The following is a description of a gene set: Human Gene Set: GOBP_REGULATION_OF_PROTEASOMAL_UBIQUITIN_DEPENDENT_PROTEIN_CATABOLIC_PROCESS studied in species Homo sapiens Any process that modulates the frequency, rate or extent of the breakdown of a protein or peptide by hydrolysis of its peptide bonds, initiated by the covalent attachment of ubiquitin, and mediated by the proteasome., and this is the list of marker genes: TF, UBE2K (ubiquitin conjugating enzyme E2 K), PBK, TAF1, PLK3, PABPN1L, DDA1, ZFAND2A, LRRK2, DDRGK1, GSK3B, FBXO22, DET1, NKD2, DESI1, SENP1, KLHL40, CSNK1E, STUB1, USP7, ARHGAP5-AS1, ZER1 (zyg-11 related cell cycle regulator), GLMN, MAPK9, CDC20B, SH3RF3, BAG2, UBXN1, XPO1, RAD23A, HSPBP1, CAMLG, SMAD7, AURKA, ZYG11B, RACK1, AKT1, DVL1, RAD23B, CDK2, CSNK2A2, GNA12, TRIM39 (NCBI Gene Id 56658), RPL11, EIF3H (NCBI Gene Id 8667), PRKN, PARK7, SOCS4 (NCBI Gene Id 122809), RYBP, SUMO2, PAQR3, OGT, NOP53, PABIR1, PSMD10, CBFA2T3, MTM1, AXIN2, HSPA1B, HFE, MDM2 (MDM2 proto-oncogene), PSEN1 (NCBI Gene Id 5663), GABARAP, FBXW8, BBS7, FHIT, WAC, HSPA1A (heat shock protein family A (Hsp70) member 1A), SH3RF1, SHH, IL33, SIRT2, CSNK2B, UBQLN4, PIAS1, UFL1, CEBPA (CCAAT enhancer binding protein alpha), STYX, USP26, MAP1A, BAG6, PHF20L1, PLK1, BAG5, CSNK1A1, RCHY1, GIPC1, DAB2, SOCS5, VCP, COMMD1, CLU, NUB1, TRIB3, TAF9, FZR1, SH3RF2, CSNK1D, GSK3A, USP38, PRICKLE1, USP5, RBX1, FOXF2, TLK2, SUMO1, N4BP1, ZNF418, CSNK2A1, GBA1, KEAP1, TTC36, TRIB1, CCAR2, RNF180, CHFR, GCLC, ARAF, RFPL1, ELOB, COP1, CDC20, SIRT1, HECTD1, USP9X, UCHL5, AXIN1, HSP90AB1, HAMP, TRIB2, DNAJB2, WNT10B, PANO1, SMARCC1, SIRT6